The following is a description of a gene set: studied in species Homo sapiens Genes in the cancer module 326. Human Gene Set: MODULE_326, and this is the list of marker genes: ALOX5AP, PTGS2, ALOX15B, ALOX15, LTA4H, AKR1C3, FASN, HPGD, PRKAB2, ALOX5, PTGDS, CYP4F3, PTGIS